The following is a description of a gene set: Human Gene Set: GOBP_REGULATION_OF_SYSTEMIC_ARTERIAL_BLOOD_PRESSURE_MEDIATED_BY_A_CHEMICAL_SIGNAL The regulation of blood pressure mediated by biochemical signaling: hormonal, autocrine or paracrine. studied in species Homo sapiens, and this is the list of marker genes: CORIN, MME, F2RL1, ATP6AP2, NOX1, ACE2, RASL10B, RHOA, AGTR1, PRCP, PREP, ENPEP, CTSG, OXTR, NOS3, EDN3 (endothelin 3), F2R, ANPEP, DRD5, CPA3, AGTR2, ECE1, ADRB2, RPS6KA2, EDNRB, ACE, PCSK5, SUCNR1, CMA1, CTSZ (NCBI Gene Id 1522), AVPR1B, MAS1 (MAS1 proto-oncogene, G protein-coupled receptor), SLC2A5, AGT, ADRA1A, ADRB1 (NCBI Gene Id 153), SERPINF2, REN, TACR1, TPM1, NDST2, CYP11B2, CYBA, AVPR1A, MRGPRD, ADRB3, GJA5, EDN2, SOD2, HSD11B2, OR51E2, COMT, AVPR2, EDN1